Given this list of marker genes Gucy1a1, Cbs, Gucy1b2 (NCBI Gene Id 239134), Thap4 (NCBI Gene Id 67026), Gucy1b1, here is a description of the gene set: studied in species Mus musculus Binding to nitric oxide (NO). Mouse Gene Set: GOMF_NITRIC_OXIDE_BINDING